Given this list of marker genes Trpv4, Tmem63b, Tmem63c, Pkd2l1, Trpa1, Scn7a (NCBI Gene Id 99039), Tmem63a, here is a description of the gene set: Mouse Gene Set: GOMF_OSMOSENSOR_ACTIVITY Sensing extracellular osmolarity to initiate a change in cell activity, and spanning the membrane of the cell. species: Mus musculus